Given this list of marker genes Gna13, Mfn2, S1pr2, Trib1, Efemp2, Sod2, Npr1, Ifng, Gstp2, Trp53, Apln, Ang5, Ppargc1a, Pten, Apod, Ndrg2, Ogn, Igfbp3, Drd4, Ilk, Tafa5, Esr2, Il10, Hmox1, Vipr2, Ptgir, Comt, Bmp2, Cdkn1a, Npr3, Vip, Rbm10, Mef2c, Il12a, Timp3, Ang6, Apoe, Ptgis, Park7, Myocd, Ace2, Gper1, Klf4, Pparg, Tnfaip3, Il12b, Bmpr2, Agt, Cnn1, Rgs5, Prkg1, Pik3r1, Gstp1, Sf1, Cav1, Pdcd4, Nppb, Ctnnbip1, Adipoq, Ang, Rhoa, Aif1, Ang2, Ppard, Tpm1, Ndrg4, Cdkn1b (NCBI Gene Id 12576), Nos3, Esr1, Il15, Gna12, Igfbp5, Ang4, Tgfb3, here is a description of the gene set: Any process that stops, prevents or reduces the rate or extent of smooth muscle cell proliferation. Mouse Gene Set: GOBP_NEGATIVE_REGULATION_OF_SMOOTH_MUSCLE_CELL_PROLIFERATION species: Mus musculus